The following is a description of a gene set: Human Gene Set: GOMF_PH_DOMAIN_BINDING studied in species Homo sapiens Binding to a PH domain (pleckstrin homology) of a protein, a domain of about 100 residues that occurs in a wide range of proteins involved in intracellular signaling or as constituents of the cytoskeleton., and this is the list of marker genes: EPHA4, LSM4, EPB41L2, NCL, INPP5A, ZNF592, SESN2, LONP1